Given this list of marker genes Nudt4, Enpp3, Nudt3, Nudt11, Nudt10, here is a description of the gene set: Mouse Gene Set: GOMF_BIS_5_ADENOSYL_PENTAPHOSPHATASE_ACTIVITY studied in species Mus musculus Catalysis of the reaction: P1-P6-bis(5'-adenosyl) pentaphosphate + H2O = AMP + adenosine 5'-tetraphosphate.